Given this list of marker genes Chrd (chordin), Six1, Bmp4 (NCBI Gene Id 12159), Ednra, Nog (noggin), here is a description of the gene set: species: Mus musculus Partitioning the insect head anlage into a fixed number of segmental units. The number of segments composing the insect head has long been a subject of debate, but it is generally agreed that there are 6 or 7 segments. From anterior to posterior the head segments are the procephalic segments (labral, (ocular), antennal and intercalary) and the gnathal segments (mandibular, maxillary and labial). Mouse Gene Set: GOBP_HEAD_SEGMENTATION